The following is a description of a gene set: A cleft of the muscular (soft) portion of the palate that is covered by mucous membrane. Soft-palate submucous clefts are characterized by a midline deficiency or lack of muscle tissue. studied in species Homo sapiens Human Gene Set: HP_SUBMUCOUS_CLEFT_SOFT_PALATE Submucous cleft soft palate, and this is the list of marker genes: KCNK9, STAC3, TP63, IPO8, GRHL3 (NCBI Gene Id 57822), UBB (ubiquitin B), SON, ZSWIM6, NONO, NEK1, POLR3A